Given this list of marker genes PRELP, SERPINA5, COL10A1, DEFA1, MGP, C17orf58, WNT2B, ADAMDEC1, LEFTY2, SHH, CBLN1, CLEC14A, CMA1, FIBCD1, LUM, FREM3, ANGPTL4, ANGPTL7, COL11A2, A1BG, ADAM11, AGRN, COL13A1, ADAMTS10, HRG, C1QC, WNT5B, COL14A1, S100A10, ANGPT1, PLAT, PLOD2, S100A4, IGFBP7, PCOLCE, ASPN, ANXA4, AZGP1, FN1, LAMB3, ADAM19, NID2, SPOCK1, MATN3, COLQ, COL17A1, CILP, HRNR, COL4A3, CCN2, ADAMTS20, HMCN1 (hemicentin 1), PODN, ADAMTSL4, FMOD, TNR, ADAMTS9, CHADL, SERPINB1, ECM1, F3, FGF10, ITIH2, COLEC12, PF4, VCAN, TIMP3, COL2A1, FCN1, ITIH5, FCN3, COL3A1, FGA, AHSG, CTSL, ANXA1, F13A1, SERPINH1, PRSS1, AGT, FBN2 (fibrillin 2), TINAGL1, FLG, BGN, SOD3, ADAMTS8, SERPINA1, ANGPT4, CTSC, EDIL3, APOE, THBS1, ANXA2, PLOD1, COL12A1 (NCBI Gene Id 1304), LTBP3, SEMA7A, SBSPON, COL4A5, DCN, COL7A1, HMCN2, HTRA1, LTBP4, COL4A2, LGALS4, FBLN2, A2M, CTSZ, LGALS3, MMP2, SEMA3B, AMBP, FRAS1, AMELY, F7, PRG4, SDC3, MYOC, TNC, ECM2, MATN1, BCAN, COL9A1, MFAP2, INHBE, COL6A3, COL5A3, LAMC1, THSD4, BCAM, EYS, PRTN3, COL18A1, WNT2, SPON1, COL27A1, LAMA5, ZP2, PRG3, ANGPT2, MFAP4, S100A7, COL24A1, SSC5D, OGN, S100A6, ANXA11, CLU, ADAMTS1, SERPINF2, IMPG1, HAPLN2, ITIH4, L1CAM, S100A9, PZP, ZP4, ICAM1, ELN, SERPINC1, ZP3, MUC2, HAPLN1, PLG, GDF15, ANGPTL6, EGFLAM (EGF like, fibronectin type III and laminin G domains), VWC2, CTSG, FGL1, COL9A3, COL6A6, ORM1 (orosomucoid 1), ADAMTS4, IFNA2, ANGPTL2 (angiopoietin like 2), VWA1, TPSB2 (tryptase beta 2), VIT, HAPLN4, TGFB1I1, APOA1, TGM4, LTBP1, P3H1, AMELX, FREM1, PCSK6, C1QB, FBLN5, MFGE8, MFAP5, TIMP2, LAMA2, GDF10, COCH, COL11A1, CTSD, CXCL12, NCAM1, F12, S100A8, TPSAB1, TGFB3 (transforming growth factor beta 3), MMP28, FCN2, NAV2, MXRA5, TGFB2, SDC2, C1QA, COL8A1, EFEMP1, COL1A2, COL16A1, ZP1, FBLN1 (NCBI Gene Id 2192), SOST (sclerostin), DAG1, MMP8, TNXB, COL20A1, MXRA7, MUC17, LAMC2, PDGFB, MMP23B, LOXL4, KAZALD1, HSPG2, ANXA5, TGM2, COL4A6, APOA4, ADIPOQ, POSTN, APOH, SERPINE2, FGFBP3, PTPRZ1, COL5A1, LOX, HNRNPM, KNG1, LGALS1, CFP, COL25A1, MATN2, CSTB, SLPI, SERPINB12, HPX, COL4A1, IMPG2, NPNT, COMP (cartilage oligomeric matrix protein), PRG2 (NCBI Gene Id 87065, proteoglycan 2, pro eosinophil major basic protein), COL23A1, ANXA6, RTBDN, GREM1, LAMB1, FGB (fibrinogen beta chain), PODNL1, SULF1, CDH13, THBS3, COL15A1, LMAN1L, LOXL2, COL19A1, MARCO, HSP90B1, CBLN4, SERPINA3, SPARC, CDH2, GH1, F9, FBN1, ANGPTL3, SRPX, RARRES2, LMAN1, COL1A1, MMP9, ELANE, TGFB1, NDP, PSAP, SERPINB8, SPP2, COL5A2, CDON, GPC1, IL7, ORM2, APCS, ANGPTL5, COL6A2, VWF, SERPINB9, DEFA1B, ANXA8, COL6A5, SFRP1, COL6A1, CRELD1, NID1, ZG16, FGG, IGFBPL1, ITIH1, CTSF, FGFR2, SERPINF1, THBS4, LTBP2, PLOD3, MDK, LGALS3BP, FGL2, TNN, SERPINB6, CTSB, KRT1, TGFBI, F2, LGALS9, CCN1, OTOL1, CTHRC1, CLEC3B, WNT8A, SERPING1, MST1, DPT, MATN4, LAMA3, ADAMTS3, COL8A2, EMILIN3, AEBP1, COL26A1, LOXL1, APOC3, CLC, THBS2, NPPA, COL9A2, CTSS, HDGF, PXDN, ANGPTL1, SFRP2, PKM (NCBI Gene Id 8127), COL28A1, MMRN1, SRPX2 (NCBI Gene Id 27286), LOXL3, FREM2, COL4A4, WNT5A, ACAN, CTSH, SERPINE1, ABI3BP, LAMB2, ESM1, CPA3, LAMA4, CSPG4, NCAN, CCDC80, MMRN2, ANXA7, HAPLN3, COL21A1, PLSCR1, EFEMP2, EGFL7, LAMA1, EMILIN1, VTN, LRRC15, RBP3, EMILIN2, here is a description of the gene set: An extracellular matrix consisting mainly of proteins (especially collagen) and glycosaminoglycans (mostly as proteoglycans) that provides not only essential physical scaffolding for the cellular constituents but can also initiate crucial biochemical and biomechanical cues required for tissue morphogenesis, differentiation and homeostasis. The components are secreted by cells in the vicinity and form a sheet underlying or overlying cells such as endothelial and epithelial cells. studied in species Homo sapiens Human Gene Set: GOCC_COLLAGEN_CONTAINING_EXTRACELLULAR_MATRIX